Given this list of marker genes STIL, VPS4B, CENPJ, NUP62, POC1B, CEP295, PLK4, CEP120, SASS6, CCDC15, PPP1R35, here is a description of the gene set: Human Gene Set: GOBP_POSITIVE_REGULATION_OF_CENTRIOLE_REPLICATION Any process that activates or increases the frequency, rate or extent of centriole replication. species: Homo sapiens